Given this list of marker genes PPP2R3A, PPP2R2D, AKT1, PPP2R2B, PPP2CA, AKT2, PPP2R5E, PPP2R5C, PPP2R2A, PPP2R2C, PPP2R1B, PPP2CB, PPP2R5A, PPP2R1A, PPP2R3C, AKT3, PPP2R3B, PPP2R5D, PPP2R5B, here is a description of the gene set: Human Gene Set: KEGG_MEDICUS_REFERENCE_PP2A_AKT_SIGNALING_PATHWAY studied in species Homo sapiens Pathway Definition from KEGG: PP2A -| AKT PP2A-AKT signaling pathway. Pathway ID: N00355. Pathway type: Reference. Pathway class: nt06530 PI3K signaling.